The following is a description of a gene set: Human Gene Set: GOBP_REFLEX An automatic response to a stimulus beginning with a nerve impulse from a receptor and ending with the action of an effector such as a gland or a muscle. Signaling never reaches a level of consciousness. species: Homo sapiens, and this is the list of marker genes: SLC1A1, TMC2, ZPLD1, ASCL1, GLRA1, NPNT, ADRA1A, HPN, GLRB, NR4A3, SLITRK6, SCN11A, TMC1, USP46 (NCBI Gene Id 64854), DRD3, SHANK1, NPSR1, ALDH1A3, NMBR, AFG3L2, NMB, FOXP2, CACNG2